Given this list of marker genes ITGA10, ITGA5, ITGB3, ITGA3, ITGA2, ITGB2, ITGB6, ITGAV, ITGB5, TNC, ITGAM, ITGA9, ITGAL, CD47, ITGB7, ITGAE, here is a description of the gene set: species: Homo sapiens Genes in the cancer module 275. Human Gene Set: MODULE_275